Given this list of marker genes MAPKAPK2, CYP4F22, CYP4A22, CYP4F8, DPEP1, PTGR1, CYP4A11, CYP4F11, GGT1, ALOX15, DPEP2, GGT5, LTC4S, ALOX5, LTA4H, CYP4F2, CYP4B1, ALOX5AP, CYP4F3, ABCC1, here is a description of the gene set: Human Gene Set: REACTOME_SYNTHESIS_OF_LEUKOTRIENES_LT_AND_EOXINS_EX Synthesis of Leukotrienes (LT) and Eoxins (EX) species: Homo sapiens